Given this list of marker genes ADPRM, NUDT18, NUDT16, NUDT15, NUDT9, NUDT1, NUDT5 (nudix hydrolase 5), here is a description of the gene set: Enzymes that belong to the NUDT (Nudix) superfamily catalyze the hydrolysis of phosphodiester bonds in molecules including nucleoside triphosphates and diphosphates and nucleotide sugars. Family members are defined by the presence of an amino acid sequence motif shared with the E. coli MutT gene product, and are involved in diverse physiological processes.<p>The hydrolysis of nucleoside di and triphosphates whose purine bases have been oxidized, deaminated, or methylated may protect the cell from the mutational damage that would occur if modified deoxyribonucleotides were incorporated into DNA and from the aberrant protein synthesis that would occur if modified ribonucleotides were incorporated into mRNA. The hydrolysis of ADP ribose may prevent the aberrant spontaneous ADP ribosylation of cellular proteins that could occur were this molecule to accumulate to high levels in the cell. species: Homo sapiens Reactome Pathway: Phosphate bond hydrolysis by NUDT proteins part of: Purine catabolism